Given this list of marker genes CHN2, RBM44, LINGO2, GRM5, CPEB3, SYNCRIP, HINT3, SLC35C1, MACF1, MFF (NCBI Gene Id 56947), CYBRD1, MED13, GRID2, RHOA, DCP2, YPEL5, ERC1, RHBDD1, SLIT3, OMG, SYS1, TTC7B, ZNF708, WDR45B, SLC38A2, SRPK1, CYBB, MPP7, STXBP5, TFAM, FLRT3, MYRIP, ACVR2A, ATXN7, TTPA, IL33, PDCD6IP, AP3B1, SAMSN1, GLIPR1L2, WDR64, ZNF225, XDH, NAA50, E2F3, LRP12, PUM1 (NCBI Gene Id 9698), LRIG1, ZNF45, MUC15 (mucin 15, cell surface associated), CPEB2, PIGA, CALM2, ELK3, ABL2, CCDC174, RAN, RAPGEF3, DPP10 (NCBI Gene Id 57628), OLFM3, MEF2A, NFYB, TMEM179B, MAGI2, XKR6, MRTFB, ZIC4, UBE3C, MRNIP, ADO, GMFB, AQR, MAP2K1, TOMM70, OR2H1, ADAM10, MID1, AKR1D1, HIBCH, AKT3, CLTC, GABPA, CUL4B, MTMR4, MBNL2, ZNF257, REEP5, C2orf88, JADE3, CSF2RB, DESI2, TSTD3, ENTHD1, OXR1, RAP1A (RAP1A, member of RAS oncogene family), SCG2, MED12L, ZFP91, SMIM13, UGT2A3, ZNF681 (zinc finger protein 681), GPC6, RGS1, NECTIN3, EDIL3, DUSP8, LATS2, NOD2, NRG1, DPP6, USP43, here is a description of the gene set: species: Homo sapiens Human Gene Set: MIR4645_3P Genes predicted to be targets of miRBase v22 microRNA hsa-miR-4645-3p in miRDB v6.0 with MirTarget v4 prediction scores > 80 (high confidence targets). from publication Chen Y, Wang X (PMID 31504780)